The following is a description of a gene set: Human Gene Set: HP_RESTING_TREMOR A resting tremor occurs when muscles are at rest and becomes less noticeable or disappears when the affected muscles are moved. Resting tremors are often slow and coarse. species: Homo sapiens Resting tremor, and this is the list of marker genes: GCH1, ATP6AP2, MT-TT, TWNK, RRM2B, FTL, CYP27A1, PARK7, TAF1, FMR1, DNMT1, PLA2G6, SNCA, UQCRC1, SMC1A, GBA1, ATXN8OS, PSAP (prosaposin), MECP2, MAPT, NR4A2, VPS13A, ATP13A2, SLC25A4, POLG2, SNCAIP, POLG, EIF4G1, FBXO7, GIGYF2 (GRB10 interacting GYF protein 2), DNAJC6, ADH1C, PTPA, ATXN3 (ataxin 3), LRRK2, NTNG1, ALDH18A1, RAB39B, KCNN2, VPS13C, ADCY5, OPA3, MICU1, COQ2, SYNJ1, ATXN2, CDKL5, MAN1B1, DNAJC13, PRKN, TBP, CHCHD2, CACNA1G, PTRHD1, PODXL, GABBR2, VPS35, ATP1A3, PINK1, TTC19